The following is a description of a gene set: Human Gene Set: REACTOME_INTRINSIC_PATHWAY_FOR_APOPTOSIS Intrinsic Pathway for Apoptosis studied in species Homo sapiens, and this is the list of marker genes: UACA, BID, YWHAH, NMT1, YWHAB, E2F1, GSDMD, AVEN, YWHAG, BCL2L1, YWHAZ, TP53, SFN, APIP, AKT2, APAF1, CDKN2A, CARD8, BAX, DYNLL2, MAPK8, XIAP, TP73, BMF, PPP3R1, MAPK1 (NCBI Gene Id 5594), SEPTIN4, STAT3, TFDP1, PPP1R13B, CASP3, TFDP2, PPP3CC, DIABLO, BBC3, PMAIP1, TP63, GSDME, CYCS, MAPK3, TP53BP2 (tumor protein p53 binding protein 2), GZMB, AKT3, YWHAQ, C1QBP, YWHAE, AKT1, BCL2L11, BCL2, BAD, DYNLL1, CASP9, CASP7, BAK1, CASP8 (NCBI Gene Id 841)